Given this list of marker genes FOXM1, SLC16A1, OR2S2, PLIN1, DNMT1, ERI2, PEX5L, JADE3, RPA3, RHOBTB3, RAC1, SKA1, RHAG, ATN1, MAST2, PPME1, CKAP5, CDADC1, ABCA4, ZNF835, TMSB15B, PKP4, DCN, TUBA1C, GLUL, NTRK3, BAIAP3, DHFR, KIR2DS3, TMEM106C, GINS3, DMC1, ATG10, KIF4A, PCBD1, SLC39A9, SEZ6L2, PMAIP1, SMARCD1, PSMA6, REPIN1, PAK4, RHEB, GNAQ, GAB2, DNTT, CBFA2T3, DONSON, C6orf15, POLA1, TP63, CDC42EP4, CNTLN, PSG1, PRC1, EZH2, SPAG5, HELLS, TMPO, DDX11, BRIP1, CCNB1, KANK1, RNASE6, H3C12, KPNA2, PLS1, CENPF, RUSC2, HOXA10, HNRNPD, ELOVL5, DOCK1, MYB, PKMYT1, KIF2C, DLGAP5, BMAL2, RRM2, MACROH2A1, SLC1A4, SERPING1, SHQ1, FADS1, MEGF9, FAM90A1, NEK2, CHAF1A, CENPU, CDK1, TMEM8B, HCK, CTNND1, NCR1, KIF11, LILRB2, PCLAF (PCNA clamp associated factor), NUSAP1, ADAMTS1, RAD51, CYP2E1, ASF1B, RPL39L, TUBB6, MAT2A, REXO5, RFC3, DYRK3, COL14A1, PRKDC, PPP2R3A, SMAD1, ANXA1, UCK2, SPHK1, TNFRSF21, EFEMP1, MRPL11, DTL, FZD6, DAB2, KIF15 (NCBI Gene Id 56992), JAM2, DZANK1, TENM4, CRYGB, ALDH1B1, INSIG1, ST6GALNAC2, NCAPD3 (non-SMC condensin II complex subunit D3), DUSP1, GINS1, PTCH2, HMGB3P1, MKI67, NCAPH, RAD51AP1, E2F8, KIF20A, EDDM3A, ERI3, KCNE2, BTG4, TROAP, CAVIN2, RFC4, TXN, CTSG, TYMS, BBOF1, CDC25A, TPX2, H2AZ1, KIF14, AUNIP, EXO1, C7, CCDC88A, CD99, PRODH, GMNN, PIEZO1, NREP, TNFAIP2, MAN1A1, CDC45 (NCBI Gene Id 8319), ASPM, MDFIC, IFT122, HOXA9, SELP, MSH6, INSR, POLA2, PCNA, CDCA4, MELK (NCBI Gene Id 9833), TOP2A, OIP5, AURKA, PSG7, POLE2, ZWINT, ADA, LLGL1, UPK1B, NCAPG, SCD, ASB13, ZNF395, GNA14, MZB1, TRIP13, GUCY1B1, DHCR24, CCNB2, PHGDH, HPX, TBC1D5, here is a description of the gene set: species: Homo sapiens Human Gene Set: GSE25088_WT_VS_STAT6_KO_MACROPHAGE_DN from publication Szanto A, Balint BL, Nagy ZS, Barta E, Dezso B, Pap A, Szeles L, Poliska S, Oros M, Evans RM, Barak Y, Schwabe J, Nagy L (PMID 21093321) C57Bl/6 wild-type and STAT6 KO mice were used to study PPARg and IL-4 signaling. Bone marrow of 3 mice per group was isolated and differentiated to macrophages with M-CSF (20 ng/ml). 20 ng/ml IL-4 was used to induce alternative macrophage activation and 1 uM Rosiglitazone (RSG) was used to activate PPARg. From each mouse 4 samples were generated: 1. M-CSF, 2. M-CSF+RSG, 3. IL-4 and 4. IL-4+RSG. All compounds were added throughout the whole differentiation process, and frech media was added every other day. Control cells were treated with vehicle (DMSO:ethanol). After 10 days, RNA was isolated and gene expression profiles were analyzed using Mouse Genome 430 2.0 microarrays from Affymetrix. Genes down-regulated in bone marrow-derived macrophages: wildtype versus STAT6 knockout.